The following is a description of a gene set: studied in species Homo sapiens Human Gene Set: GOBP_REGULATION_OF_PHOSPHATASE_ACTIVITY Any process that modulates the rate or frequency of phosphatase activity. Phosphatases catalyze the hydrolysis of phosphoric monoesters, releasing phosphate., and this is the list of marker genes: GPLD1, EPM2A, CDK5RAP3, URI1, CHP1, PPP1R17, MTMR9, CHP2, BMP2